Given this list of marker genes Kcnq1 (potassium voltage-gated channel, subfamily Q, member 1), Kcnd3, Kcne1, Kcnj8, Scn2b, Kcne4, Kcne5, Kcnh2, Kcne3, Kcne2, here is a description of the gene set: studied in species Mus musculus Enables the transmembrane transfer of a potassium ion by a voltage-gated channel through the plasma membrane of a ventricular cardiomyocyte contributing to the repolarization phase of an action potential. A voltage-gated channel is a channel whose open state is dependent on the voltage across the membrane in which it is embedded. Mouse Gene Set: GOMF_VOLTAGE_GATED_POTASSIUM_CHANNEL_ACTIVITY_INVOLVED_IN_VENTRICULAR_CARDIAC_MUSCLE_CELL_ACTION_POTENTIAL_REPOLARIZATION